Given this list of marker genes OXCT1, TIPARP, TOR3A, GJA1, NFKBIA, CD86, BMP2K, PCGF5, YWHAG, FLOT2, CHMP4B, STAM, IRF9, RIOK3, KCNK1, UBALD2, PFKP, SOCS1, EDF1, FNDC3A, CH25H, STAT3, FBXL5, VCAN, NAMPT, GBP7, GADD45G, RNF19B, APAF1, BUD31, PNP, CDKN2D, RAB5C, GUCA1A, RNF149, IRF1, CCR1, FCGR1A, SLC41A1, DCAF13, TBC1D14, ST6GALNAC4, MYD88, AFF1, NFKB1, BZW2, MAP3K3, BCL3, MT1E, ARHGEF3, GAB1, CXCL10, HSPA8, LITAF, AGFG1, INPP5B, CAPN2 (NCBI Gene Id 824), GADD45A, NR3C1, RAB3IL1, GK (NCBI Gene Id 2710), IFIT2, NFKBIZ, MARCHF5, GCLM, ST3GAL4, SOCS2 (NCBI Gene Id 8835), UBXN8 (NCBI Gene Id 7993), GBP4, SELP, NSMCE1 (NSE1 homolog, SMC5-SMC6 complex component), ILRUN, NUP54, MACIR, ZNF281, RRBP1 (NCBI Gene Id 6238), FH, FOXB1, TIRAP, PLA2G4A, ZNFX1, NOP58, MT2A, CCL7, IFIH1, LCP2, CUL2, IL17RA, TNFRSF1A, PSMB9, PAK1IP1, LYN, SERTAD1, TM2D2, LTV1, IL4R, PTPN1, TXNRD1, FGL2, ATF6, MCOLN2, SPTLC2, ISG15, ID1, CSF2RB, PLSCR1, TAP1, GBP2, TOR1AIP2, ETNK1, TEC, NAA38, BACH1, SUSD6, DR1, UBXN4, GCH1, AHR, EIF1AY, TMEM167A, LGALS9B, NDUFB10, JUN, TIMP1, MIDN, PSMC3, TLE3, SLC2A1, VTA1, TRAF6, TGFBI, HK2, IFI35, ZCRB1, SLC12A7, CHD7, TNFSF9, GCNT2, CCL13, CEBPD, LARP1, CASP1, TPST1, RMDN3, SLFN12, IL13RA1, USP18, JAK1, JAK2, MAP3K8, MTERF3, BID, DDX24, IRGM, RNF34, UNC13B, UGCG, HERC4, PML, RBMXL1, ZFP36, GRK6, ZFAND5, IRF8, ADAM9, CASP4, ANKRD17, DUSP16, TRAFD1, CCL2 (C-C motif chemokine ligand 2), FCGR2B, DNTTIP2, SGCB, NOCT, PELI1, DCK (deoxycytidine kinase), PMS2, CCL4, RHBDL3, PNPT1, TIMM10B, PIM1, B4GALT3, CASP6, IL15, DAB2 (DAB adaptor protein 2), PPRC1, CD83, CCR5, TRPC1, RERE, RARS1, NDRG1, IER3, TRIR, RPL7, CYRIB, CLDND1, VMP1 (vacuole membrane protein 1), STX12, here is a description of the gene set: Studies of adult human hematopoiesis have until now relied on the expression of CD10 to define lymphoid commitment. We report a novel lymphoid-primed population in human bone marrow that is generated from hematopoietic stem cells (HSC) prior to the onset of CD10 expression and B cell commitment, and is identified by high levels of the homing molecule L-selectin (CD62L). CD10-CD62Lhi progenitors have full lymphoid (B/T/NK) potential, and show reduced myeloid and absent erythroid potential. Genome-wide gene expression analysis demonstrates that the CD10-CD62Lhi population represents an intermediate stage of differentiation between CD34+CD38- HSC and CD34+lin-CD10+ progenitors marked by down-regulation of TAL1 and MPL, upregulation of E2A, CD3E and IL2RG expression, and absent B cell commitment or RAG1/2 expression. Immature CD34+CD1a- thymocytes are also CD62Lhi and L-selectin ligands are expressed at the cortico-medullary junction, suggesting a possible role for L-selectin in human thymic homing. These studies identify the earliest stage of lymphoid priming in human bone marrow. from publication Kohn LA, Hao QL, Sasidharan R, Parekh C, Ge S, Zhu Y, Mikkola HK, Crooks GM (PMID 22941246) Genes down-regulated in the bone marrow CD34+ cells: CD38- versus MME+. species: Homo sapiens Human Gene Set: GSE35685_CD34POS_CD38NEG_VS_CD34POS_CD10POS_BONE_MARROW_DN